The following is a description of a gene set: Glycosphingolipid catabolism species: Mus musculus Mouse Gene Set: REACTOME_GLYCOSPHINGOLIPID_CATABOLISM, and this is the list of marker genes: Galc, Neu2, Arsa, Sumf2, Sumf1, Glb1, Arsb, Enpp7, Arsi, Gla, Glb1l, Gba2, Asah2, Hexb, Glb1l3 (galactosidase, beta 1 like 3), Asah1, Arsk, Psap, Gba1, Neu3, Sts, M6pr, Glb1l2, Neu4, Neu1, Arsg, Gm2a, Smpd3, Smpd4, Ctsa, Smpd2, Hexa, Smpd1, Arsj